Given this list of marker genes MIS18A, RB1, KNTC1, MIS12, CENPH, CENPF, CENPW (centromere protein W), POGZ, SUGT1, CENPC, CENPX, SENP6, TRAPPC12, H3-3A, ITGB3BP, H3-3B, OIP5, RNF4, CENPO, CENPA, CENPV, HJURP, CENPI, DLGAP5, CENPP, NASP, CENPT, CENPN, CENPK, CENPE, here is a description of the gene set: Human Gene Set: GOBP_CENTROMERE_COMPLEX_ASSEMBLY The aggregation, arrangement and bonding together of proteins and centromeric DNA molecules to form a centromeric protein-DNA complex. Includes the formation of the chromatin structures which form a platform for the kinetochore, and assembly of the kinetochore onto this specialized chromatin. In fission yeast and higher eukaryotes this process also includes the formation of heterochromatin at the outer repeat (pericentric) regions of the centromere. species: Homo sapiens